The following is a description of a gene set: Genes down-regulated in comparison of induced regulatory T cell (Treg) versus natural regulatory T cell (Treg). Multipotential naïve CD4+ T cells differentiate into distinct lineages including T helper 1 (Th1), Th2, Th17, and inducible T regulatory (iTreg) cells. The remarkable diversity of CD4+ T cells begs the question whether the observed changes reflect terminal differentiation with heritable epigenetic modifications or plasticity in T cell responses. We generated genome-wide histone H3 lysine 4 (H3K4) and lysine 27 (H3K27) trimethylation maps in naïve, Th1, Th2, Th17, iTreg, and natural (n)Treg cells. We found that although modifications of signature cytokine genes (Ifng, Il4, and Il17) partially conform to the expectation of lineage commitment, critical transcription factors such as Tbx21 exhibit a broad spectrum of epigenetic states, consistent with our demonstration of T-bet and IFN-gamma induction in nTreg cells. Our data suggest an epigenetic mechanism underlying the specificity and plasticity of effector and regulatory T cells and also provide a framework for understanding complexity of CD4+ T helper cell differentiation. species: Homo sapiens Human Gene Set: GSE14308_INDUCED_VS_NATURAL_TREG_DN from publication Wei G, Wei L, Zhu J, Zang C, Hu-Li J, Yao Z, Cui K, Kanno Y, Roh TY, Watford WT, Schones DE, Peng W, Sun HW, Paul WE, O'Shea JJ, Zhao K (PMID 19144320), and this is the list of marker genes: ATP11C, AP3B1, PRKCH, SEMA3D, PAXBP1, SATB1, TRIM5, IGFLR1, SCML4 (NCBI Gene Id 256380), PAIP2, SETD4, LYST, ELMOD2, DNAI4, S100A9, ZBTB26, MFSD1, MARVELD1, KMT5B, SLK, GZMA, RPL30, EPC1, TTC14, KIAA0319, ATXN7, FBXO32, ESF1, FMR1, LRP6 (LDL receptor related protein 6), TAF15, DMAC2L, HBP1, MIIP, RP2, PRKX, FSD2, CCPG1, B2M, TBX6, PPM1L, DCAF15, SLC49A4, MAF (NCBI Gene Id 4094), TDRD3, THEMIS, RDH5, VILL, PAPOLG, STX4, SLC45A4, DNAJC3, NDST2, CMPK2, MLYCD, HES6, DNAJA4, NHLRC3, TBC1D4, ARB2A, LRRC61, EPX, EPS8L1 (EPS8 signaling adaptor L1), NBR1, EPB41, CXCR6, GNGT2, EIF3E, NUDT7, ARHGAP9, PAN2, STX1A, PLCL2, TRMT1L, GAB3, BCL7B, PNN, B4GALNT4, TMX4, SP3, MAP4K3, SERINC3 (serine incorporator 3), DCP1B, CPQ, SMC5, NTAQ1, ARSK, ACP3, FOXO1, UCKL1, TAF8, ZC3H7A, UBXN2A, XAB2, MMD, IK, PRODH, PSME1, AMY2A, EXOC5, OPA1, SNAPC1, MRGPRE, CCDC47, PLEKHS1, NFATC1, SLMAP, STARD3, MEIS3, STK38 (NCBI Gene Id 11329), HOOK3, UNC13D, RORA, ALKBH6, ARHGAP25, RCOR3, ZNF710, OTOR, SELENOT, NDST1, ZBTB1 (zinc finger and BTB domain containing 1), EXD2, KLF7, BMP7, RRM2B, CLCN7, RNF145, ZNF329, ITCH, MTMR10, STAM2 (NCBI Gene Id 51453), IL1RAP, ITPR2, CCDC88C, STRN (striatin), ASB5, GALNT4, IL4R, DUSP12 (dual specificity phosphatase 12), ASAH2, ZFP1, TAX1BP1, CHMP1A (NCBI Gene Id 5642), HLA-DRB1, NME3, AP1G2, EML6, PPARGC1B, PPIP5K2, LRIF1, ANKRD10, SYNJ2, TERF1, MORC3, PUS3, GIGYF2, FAU, FCER1G, DLGAP4, ARMH4, RPS11, GOLGA3, TPP1, SUPT20H (NCBI Gene Id 55578), MCOLN2, SMPD2, TBC1D9 (TBC1 domain family member 9), ABI1, DYNLT3, SP1, ZNF362, ALDH4A1, STK10, OVGP1, NXF1, PSAP, ARRDC4, TAF1A, STK4, POU5F2, C22orf39, MON2, VAT1, SNRK, PDK2, SNX13, GBF1, RAP1B, BCO2, RLF, PTPRB, MKRN1, RNF122, ZNF708, SLC26A11, CNTLN, BRD9, CYSLTR2, DNAJB14, HIVEP2 (NCBI Gene Id 3097)